The following is a description of a gene set: Human Gene Set: GENTILE_UV_LOW_DOSE_UP studied in species Homo sapiens DNA damage caused by UV radiation initiates cellular recovery mechanisms, which involve activation of DNA damage response pathways, cell cycle arrest and apoptosis. To assess cellular transcriptional responses to UVC-induced DNA damage we compared time course responses of human skin fibroblasts to low and high doses of UVC radiation known to induce a transient cellular replicative arrest or apoptosis, respectively. UVC radiation elicited >3-fold changes in 460 out of 12,000 transcripts and 89% of these represented downregulated transcripts. Only 5% of the regulated genes were common to both low and high doses of radiation. Cells inflicted with a low dose of UVC exhibited transcription profiles demonstrating transient regulation followed by recovery, whereas the responses were persistent after the high dose. A detailed clustering analysis and functional classification of the targets implied regulation of biologically divergent responses and suggested involvement of transcriptional and translational machinery, inflammatory, anti-proliferative and anti-angiogenic responses. The data support the notion that UVC radiation induces prominent, dose-dependent downregulation of transcription. However, the data strongly suggest that transcriptional repression is also target gene selective. Furthermore, the results demonstrate that dose-dependent induction of cell cycle arrest and apoptosis by UVC radiation are transcriptionally highly distinct responses. from publication Gentile M, Latonen L, Laiho M (PMID 12907719) Selected genes up-regulated in WS1 (fibroblast) in response to irradiation with low dose UV-C., and this is the list of marker genes: ZNF263, HSPA1A, PMAIP1, SYF2, GTF2H4, EFNB1, GDF15 (NCBI Gene Id 9518), SOX4, PPP1R8, TAP1, IL11, PLK2, CCDC86, H2AC18, FDXR, CCNE1, CSNK1G2, ISG15, RSL1D1, TOB1, SMOX, HSPA1B (heat shock protein family A (Hsp70) member 1B), BTG2, CDKN1A, GPRC5A